The following is a description of a gene set: from publication Yevshin I, Sharipov R, Kolmykov S, Kondrakhin Y, Kolpakov F (PMID 30445619) Human Gene Set: NR1D1_TARGET_GENES Genes containing one or more binding sites for (NR1D1) in their promoter regions (TSS -1000,+100 bp) as identified by GTRD version 20.06 ChIP-seq harmonization. species: Homo sapiens, and this is the list of marker genes: NNT-AS1, GPATCH11, MARCOL, SCLT1, AP3B1 (NCBI Gene Id 8546), RBM4B, YJU2, TSEN34, MBOAT7, LRRC40, CCNH, SRSF11, UVSSA, TAMM41 (NCBI Gene Id 84207), ELP3, NNT, CCDC38, SLC11A2, ERCC8, GPATCH8, CRELD1, MELTF, EEF2K, AMDHD1, C4orf33, ST7-AS2, JUP, BRD2, PNPT1, EMG1, HYCC2, RRM2B, IST1, ZSCAN21, DLGAP1-AS1 (DLGAP1 antisense RNA 1), PCNA, VPS26C, ARHGAP12, CFDP1, MYL12B, MTCO3P12, FAM13B, VCF1 (VCP nuclear cofactor family member 1), TRA2B, RICTOR, NOLC1, NDUFB3, PSMG1, TMEM177, TRADD, NDUFAF2 (NADH:ubiquinone oxidoreductase complex assembly factor 2), USP15, FAM222B, ZMPSTE24-DT, RRP15, TBC1D5, SLC25A12, NKIRAS2 (NFKB inhibitor interacting Ras like 2), PIK3R1, GBP1P1, FAM13B-AS1, ZMPSTE24, AMZ2P1, CMTR2, TBC1D12, HCG14, ULBP3, IKBKB, RFX1, MRPL1, HCFC1R1, BTG2-DT, MRPL54, LINC02851, C2orf68, CA5BP1, MTNAP1, IKBKB-DT, NCBP3, TRAF3IP2, ID2-AS1, QTRT1, HLA-DMA, BANP, CTSO (NCBI Gene Id 1519), H2AX, PSMB9, APC, ATRAID, APBA3, HEATR5B, RPS15, H2BC21, USP39, WWP2, NAPB (NSF attachment protein beta), INTS4, MYCL (NCBI Gene Id 4610), DENND2D, KATNB1, BTG2, C6orf120, H2AC20, EIF2S2, DDX1, WDR27, NSMAF (neutral sphingomyelinase activation associated factor), PHB2, INTS13, TAFA2, TNRC6B, LINC01232, SP4, TMEM232, RNU6-502P (RNA, U6 small nuclear 502, pseudogene), HNRNPC, SNORA73B, UBR5-DT, SLC26A11, IQCH, FBXL8, LINC-PINT